Given this list of marker genes TRBV19, LTB, GZMK, TRBV7-9, TRBV5-1, MT2A, CD27, TRBV7-6, S100A8 (NCBI Gene Id 6279), here is a description of the gene set: from publication Unterman A, Zhao AY, Neumark N, Schupp JC, Ahangari F, Cosme C Jr, Sharma P, Flint J, Stein Y, Ryu C, Ishikawa G, Sumida TS, Gomez JL, Herazo-Maya JD, Dela Cruz CS, Herzog EL, Kaminski N (PMID 38717443) Human Gene Set: UNTERMAN_PROGRESSIVE_VS_STABLE_IPF_CD8T_UP Genes upregulated in C84 T-cells from Progressive Idiopathic Pulmonary Fibrosis Patients vs. Stable Non-Progressors species: Homo sapiens Thirty-eight PBMC samples from 25 patients with IPF and 13 matched controls yielded 149,564 cells that segregated into 23 subpopulations. Classical monocytes were increased in progressive and stable IPF compared to controls (32.1%, 25.2%, 17.9%, respectively, p<0.05). Total lymphocytes were decreased in IPF vs controls, and in progressive vs stable IPF (52.6% vs 62.6%, p=0.035). Tregs were increased in progressive vs stable IPF (1.8% vs 1.1% of all PBMC, p=0.007), although not different than controls, and may be associated with decreased survival (P=0.009 in Kaplan-Meier analysis; P=0.069 after adjusting for age, sex, and baseline FVC). Flow cytometry analysis confirmed this finding in an independent cohort of IPF patients. Fraction of Tregs out of all T cells was also increased in two cohorts of lung scRNA-seq. CCL22 and CCL18, ligands for CCR4 and CCR8 Treg chemotaxis receptors, were increased in IPF. The single-cell atlas of the peripheral immune system in IPF, reveals an outcome-predictive increase in classical monocytes and Tregs, as well as evidence for a lung-blood immune recruitment axis involving CCL7 (for classical monocytes) and CCL18/CCL22 (for Tregs). (From Abstract)